The following is a description of a gene set: from publication Chen Y, Wang X (PMID 31504780) studied in species Mus musculus Mouse Gene Set: LET_7G_5P Genes predicted to be targets of miRBase v22 microRNA mmu_let_7g_5p in miRDB v6.0 with MirTarget v4 prediction scores > 80 (high confidence targets)., and this is the list of marker genes: Prtg, Igf1r, Rbms2, Klhl6, Stx17, Cry2, Asap1, Gatm (glycine amidinotransferase (L-arginine:glycine amidinotransferase)), Faxc, Syt11, Nap1l1, Dcaf15, Trim6, Peg10, Wnt9a, Col1a2, Slc35d2, Senp2, Bach1, Ppp1r16b, Thoc1, Onecut2, Mapk6, Homer2, Zfyve26 (zinc finger, FYVE domain containing 26), Sall3, Wdfy3, Smim3, Soat2, Dlc1, Ddx19a, Gcat, Ybey, Pogz, Atp2a2, Slc25a24, Lipt2, 5031439G07Rik, Bzw1, Efhd2, Tnfaip8l3, Adamts15, Pitpnm3, Gpatch3, Pcdh19, Arhgef15, Plekha8 (pleckstrin homology domain containing, family A (phosphoinositide binding specific) member 8), Rspo2, Trim41, Rdx, Tspan5, Trhde, Galnt2, P2rx1, Ptafr, Zfp975, Slc38a9, Dmd, Hif1an, Cemip2, Begain, Arhgap12, B3gnt7, Ltn1, Fndc3b (fibronectin type III domain containing 3B), Hoxa1, Rictor, Slc6a1, Hand1, Smug1, Mycn, Nme6, Rgs16, Lin28b, Cntrl, Edn1, Agap1, Arpp19 (cAMP-regulated phosphoprotein 19), Scyl3, Pik3ip1, Eef2k, Thoc2, Prpf38b, Nol4l, Nynrin, Tmco1, Dpp3, Fam135a, Lrig3, Nipal4, Fras1, Igf2bp1, Plxnc1, Cdc34 (NCBI Gene Id 216150), Mapk8, Lgr4, Arid3a, Col5a2, Cep120, Ccdc71l, Gpatch2, 2310022A10Rik, Yod1, Mycbp, Dtx4, Pcdh20, E2f2, Stx3, Slc66a1, Ttll4, Cpa4, Vstm5, Slc2a12, Dusp22, Entrep2, Lrig2, Tyk2, Igf2bp3, Cep135, Map3k2, Sowaha, Gabra6, Fbxl12, Trim71, Zswim5, Ddx19b, Usp38, Plekho1, Hdlbp, Col4a2, Prkaa2, Trabd, Acvr1c, Zfp282, Sec16b, Nemp1, Snn, Trim67, Rab8b, Gxylt1, Dnajc1, Gas7, Bsn, Kif2b, Styk1, Tmem198b, Lbr, Adamts12, Tet3, Adrb2, Rasgrp1, Hip1, Brwd1, Snx30, Ndst2, Pbx2, Acat1, Fnip1, Ccnj, Alg11, Scn11a, Kif21b, Gpr156, Tmprss2, Plxnd1, Hic2 (NCBI Gene Id 58180), Ccr7, Klk10, Slf2 (NCBI Gene Id 77718), Cercam, Dna2, Dnaja2, Slc22a23, Fndc3a, Limd2, Mdfi, Col3a1, Dtx2, Egln2, Psd3, Pbx3, Prrx1, Cbx2, Slc10a7, Sall4, Limk2, Igdcc3, Mxd1, D630045J12Rik, Hook1, Kdm3a, Cgnl1, Col27a1, Ppp2r2a, Adamts8, P4ha2, Ccnd2, Liph, Zbtb5, Intu, Has2, E2f5, Greb1l, Pard6b, Il13, Ehhadh, Plpp6, Kctd21, Zfp583, Etnk2, Tmem65, Slc7a14, Plpp5, Gng5, Stxbp5, Leprotl1, Stk40, Zfp512b, Stimate, Mdm4, Map4k4, Diaph2, Nphp3, Zbtb39, Cpeb2, Slc25a27, Wnt9b, Sigmar1, Nras, Kctd17, Stard13, Lin28a, Clasp2, Slc16a14, Macf1, Eea1, Ap1s1, Crb2, Masp1, Gpcpd1, Pald1, Map4k3, Nr6a1, Igdcc4, E2f6, Hmga2, Arid3c, Galnt1, Ddi2, Thrsp, Casp3, Cnot6l, Cldn12, Pbx1, Col4a1, 1700017B05Rik, Tgfbr1, Utrn, Gnptab, Cpeb1, Cd200r1, Tmc7, Dnase1l2, Atl2, Tbkbp1, Fnip2, Grid2ip, Zmat4, Fignl2, Rgs6, Ppargc1b, Katnbl1, Zfp275 (NCBI Gene Id 71402), Dusp1, Txlng, Tmprss11f, Brd3, Rbpj, Slc20a1, 9930012K11Rik (NCBI Gene Id 268759), Ints6l, Plekhg6, Myorg, Tgds, Arl5a, Ints2, Bcat1, Fasl, Rfx6, Usp24, Arid3b, Smarcad1, Apbb3, Tmod2, Pappa, Cbx5, Map3k1, Nek3, Ngf, Taf9b, Mfsd4a, Abcb9, Fam174a, Osmr (NCBI Gene Id 18414), Ercc6, Onecut3, Ahctf1, Pxdn, Rufy3, Tgfbr3, Alox8, G6pc2, Arhgap28, Wasl, Pde12, Gga3, Xkr8, Sestd1, Zc3hav1l (NCBI Gene Id 320578), Klf8, Rab11fip4 (NCBI Gene Id 319892), Pla2g3, Hectd2, Gdf6, Lpgat1, Igf2bp2, Elp1, Rbfox2, Fgf11, Adrb3, Pcgf3, Fgd6, Skil, Pacs2, Frmd4b, Coil, Cflar, Il6, Fign (NCBI Gene Id 60344), Gramd2b